Given this list of marker genes EP300, MACROH2A1, DVL1, SMC1A, COL5A1, TMTC3 (NCBI Gene Id 160418), ERI1, ARF1, SRCAP, ARFGEF2 (NCBI Gene Id 10564), RAD21, CSGALNACT1, GDF5, ATR (NCBI Gene Id 57307), COL5A2, RNU4ATAC, CREBBP, MAFB, CLCN3, NGLY1, BMP1, GMNN, SOX9, B3GALT6, CDC6, COL1A2, SMOC1, SLC35B2, NIPBL, ORC6, NOG, TBX5, MAP1B, AFF3, TBX15, NOTCH2, CDC45, NEDD4L, HNRNPH1, ARID1B, BRD4, WNT5A (NCBI Gene Id 7474), COL27A1, EXTL3, SALL4, SCARF2, MAP3K7, ORC1, CHST3, SMC3, FBN1, CDT1, KIF22, FLNA, B3GAT3, PITX1, CANT1, DONSON, CHRNG, SLC39A13, ASXL1, XYLT1, AEBP1, L1CAM, TAF6, SHOX, FZD2, B4GALT7, HSPG2 (NCBI Gene Id 7796), ROR2, ERMARD, GPC6, HDAC8, LRP4, EXOC6B, ERCC1, ORC4, COL1A1, CD96, SLC26A2, APC, GSC, FLNB, NXN, DVL3, IFITM5, SKI, PRKAR1A, LMNA, LMX1B, FBN2, here is a description of the gene set: Upper extremity joint dislocation Human Gene Set: HP_UPPER_EXTREMITY_JOINT_DISLOCATION Displacement or malalignment of one or more joints in the upper extremity (arm). species: Homo sapiens